The following is a description of a gene set: Mouse Gene Set: GOBP_REGULATION_OF_PROTEIN_EXIT_FROM_ENDOPLASMIC_RETICULUM studied in species Mus musculus Any process that modulates the frequency, rate or extent of the directed movement of proteins from the endoplasmic reticulum., and this is the list of marker genes: Erlec1, Derl3, Sorl1, Tmem30b, Insig1, Cd81, Sec16b, Tm9sf4, Ube2j1 (ubiquitin-conjugating enzyme E2J 1), Gcc2, Derl2, Ube2g2, Svip, Ubac2, Tmem30a, Bcap31, Os9, Slc35d3, Edem2, Edem1, Slc51b, Yod1